The following is a description of a gene set: species: Homo sapiens Human Gene Set: REACTOME_FGFR1_MUTANT_RECEPTOR_ACTIVATION FGFR1 mutant receptor activation, and this is the list of marker genes: ZMYM2 (NCBI Gene Id 7750), FGF2, ERLIN2, FGF8, FGF23, MYO18A, CEP43, LRRFIP1, STAT3, FGF1, FGF9, GRB2, CNTRL, TRIM24, FGF17 (NCBI Gene Id 8822), FGF20, FGFR1, FGFR1OP2, CPSF6, STAT1, CUX1, FGF4, FGF5, STAT5A, BAG4, BCR, STAT5B, FGF6, PIK3CA, PIK3R1, GAB2